The following is a description of a gene set: studied in species Homo sapiens Human Gene Set: GOBP_FAT_SOLUBLE_VITAMIN_METABOLIC_PROCESS The chemical reactions and pathways involving of any of a diverse group of vitamins that are soluble in organic solvents and relatively insoluble in water., and this is the list of marker genes: CYP4F12 (NCBI Gene Id 66002), CYP26A1, CYP2W1, LIPA, PLTP, IFNG, RBP2, CYP24A1, TTPA, GGCX, TNF, CYP4F3, SNAI1, LRP2, ALDH1A2, CYP27B1, PIAS4, CYP11A1, LGMN, UGT1A3, CYP4F2, CYP2R1, NPC1L1, CYP27A1, CYP26B1, RLBP1, GFI1, VKORC1L1, CBR3, LRAT, NQO1, FGFR1, CYP4F11, CBR1, FGF23, CYP4F8, RPE65, NFKB1, SNAI2, AIFM2, GC, CYP1A1, CYP3A4, CYP26C1, UGT1A4, VKORC1, RBP1, BCO1, UBIAD1